The following is a description of a gene set: Human Gene Set: MIR3675_5P from publication Chen Y, Wang X (PMID 31504780) species: Homo sapiens Genes predicted to be targets of miRBase v22 microRNA hsa-miR-3675-5p in miRDB v6.0 with MirTarget v4 prediction scores > 80 (high confidence targets)., and this is the list of marker genes: ZFP64, SLC22A23, TESK2, FGFR2, GIMAP4, ZNF189, MAMLD1, PATL1, SYNPO2L, XRCC4, KNTC1, BBS4, KLHL23 (kelch like family member 23), WIPF1, ARHGAP24, NFATC2IP, SNAPC2, NEUROD4, EPHA4, FGF13, AMFR, GALNT6, MARCHF1, SGTB, PHLPP2, JADE3, RAP1B, ABHD4, RALGAPA1, OAS1, CELSR2, ZNF101, EPB41L5, RTL5, ARHGAP32, ARHGAP6 (Rho GTPase activating protein 6)